The following is a description of a gene set: species: Mus musculus A complex system of membrane-bounded compartments located between endoplasmic reticulum (ER) and the Golgi complex, with a distinctive membrane protein composition; involved in ER-to-Golgi and Golgi-to-ER transport. Mouse Gene Set: GOCC_ENDOPLASMIC_RETICULUM_GOLGI_INTERMEDIATE_COMPARTMENT, and this is the list of marker genes: Vmp1, Ergic2, Zdhhc20 (zinc finger, DHHC domain containing 20), Nat8f7, Golga2, Hmgb1, Rab2a, Mtmr6, Stx17, Cnih4 (NCBI Gene Id 98658), Piezo1, Nat8, Tmed5, Tmed10-ps, Nat8f5, Stx5a, Lman1 (NCBI Gene Id 70361), Atp2a1, Vma21, Lman2l, Copg1, Pdia6, Rab6b, Slc35c2, Lrpap1, Golgb1, Copz2, Nat8b-ps, Il1f10, Nucb1, Rab37, Yif1b, Kdelr1, Car4, Yif1a, Mydgf, Tmed6, Rgmb, Gnpnat1, Yipf7, Tm6sf2, Nucb2, Chp1 (calcineurin-like EF hand protein 1), Robo1, Mppe1, Mcfd2 (NCBI Gene Id 76352, multiple coagulation factor deficiency 2), Surf4, Golga3, Ddhd2, Tmed3, Sec22b, Ist1, Plpp3, Tmed7, Cln8, Trappc12, Hspa5, Ergic1, Ergic3, Gbf1, Tmed4, Trappc5, P4hb, Ftcd (formiminotransferase cyclodeaminase), Rer1, Dcstamp, Ecpas, Bcap31, Prom1, Lamp5, Anpep, Nat8f2, Atp6ap1, Nat8f1, Nat8f6, Trip11, Trappc2, Fn1, Ccdc115, Tmem199, Erp44, Nat8f3, Copg2, Lman1l, Tmed2, Tmed10, Mgat4a, Rab1b, Scyl1, Smo, Lman2, Tmed1, Tmed11, Vps13b, Inpp5b, Dicer1, Mgat4b, Man1a (NCBI Gene Id 17155), Ptpn2, Copb1, Nat8f4, Myo18a (myosin XVIIIA), Azin2, Tmem203, Sppl3, Whamm, Stk17b, Sting1, Uggt1, Aspscr1, Serpinh1, Tmed9, Prrg4, Mgat4d